Given this list of marker genes KHDRBS1, TUBB2A, NUDT4 (nudix hydrolase 4), RHOA, MTFR1, AMMECR1L (NCBI Gene Id 83607), BCL11B, BHLHE41, ID2, BASP1, BTF3L4, PRDM1, RAP2C, PHLDB1, NOG, FAM219A, REV1, EVI5, OGT, CLASP2 (cytoplasmic linker associated protein 2), CFL2, ATP2A2, PCDH8, FBXW11, SYVN1, RAC1, CDK16, TARDBP, DAG1, HIPK1, KRAS, PTHLH, BAZ2B, NUP153, SCN3B, CDK2AP1, FGFR2, AMFR, NTF3, ADCY2, PTPN13, SYT1 (synaptotagmin 1), CDK17, ORMDL3, LRP4, SLC6A1 (NCBI Gene Id 6529), FGD1, ACVR2A, UBE2I, FIGNL2, MMD2, RLF, SEMA6D, CSNK1G3, SMG8, MMD, ZMYM4, WBP1L, ZCCHC24, ARHGDIA, MATR3, LRP1, SLITRK1, FN1, OCLN, TRAPPC14, ELF2, PHF21B, NAV3, REEP1, RGL1, CNOT7, CAB39, ITPR1, KCNQ4, SESN1, PLPPR1, MPRIP, DNMT3A, HDHD2, OTUD4, TUBB, CLASP1, RAB7A, OXR1, HLF, CNOT4 (CCR4-NOT transcription complex subunit 4), TRIM33, TSC22D2, ASAP1, NPTX1, SLC16A12, LHFPL6, SOX1, LRP1B, TLN2, BMI1, RDH10, DACH1, SRSF1, EPS8, DACT1, SH3PXD2A, PDS5B, DNAJB6, SRF, MEX3C, CBX4, RHOT1, WAPL, SDC2, ATXN1, HMGB3, FEZ2, YWHAB, FMR1, TBP, UBE2W, ARPP21, GOLGA6L9 (golgin A6 family like 9), LRRTM3, TRIL, DUSP1, ARHGEF17, KCND2, MTUS1, SLC6A6, PPP2CA, PARP6 (poly(ADP-ribose) polymerase family member 6), NFIA, JAZF1, NDN, TSC22D1, ANK3, DCUN1D1 (NCBI Gene Id 54165), SYDE1, DMRT2, MYCN, UBQLN1, BPTF, CSMD3, NDST1, ANLN, CTNND2, NCOA2, NEGR1, VEZF1, TBK1, E2F3, HMBOX1, PSIP1, CILK1, ESRRG, ASXL1, SMURF2, SBF1, NIN, PIKFYVE, CDH11, KCTD8, ANKRD28, AMOTL2, MAP4K3, KRT80, PRKACB, PIN1, EGR3, SOX2, APPL1, VEGFA, DDX3X, CNN3, HSPA9, CNEP1R1, RND3, YPEL2, TMEFF2, NIPA1, LPAR1, ADIPOR2, ZFPM2, PHF6, ID2B, HECTD2, TRIM2, OSBPL11, TMEM70, CTDSPL2, SIAH1, PPP4R2, KCTD15, KLF9, WIPF1, HNRNPK, PENK, CDYL, SLC14A1, ZFAND6, KCNJ2, PCNP (PEST proteolytic signal containing nuclear protein), RTF1, FBXO33, ELOC, AEBP2, LMO7, PAM, RPS6KA2, COPS8, TRAM1L1, SSH2, TAF4, QKI, MBOAT2, NAB1, CEP350, PAPOLA, GOLGA8EP, SNAP25, GOLGA7, GNAI3, STX1A, ARID2 (AT-rich interaction domain 2), SYNJ1, SMARCD1, ARID4B, EFNA1 (ephrin A1), NCS1, MFAP5, VLDLR, RNF5, GLI3, MSL2, TOB1, NPM1, NRP2, SMARCAD1, FLI1, FNDC3B, FHL1, PUM2, FBXW2, ETV5, PLCL1, PALS1, ZC3H15 (zinc finger CCCH-type containing 15), CNTN4, TRMT9B, BRMS1L, ZIC3, XKR6, PCDH7, ERRFI1, NR3C1, ZNF217, SCAMP1, AFF3, CEP41, RABIF, KCNK2, C6orf62, HS2ST1, WDFY3, SLC16A2, PPP2R5C, NUFIP2, ZNF532, FOXG1, MBLAC2, TUBB3, AP1S2, KLF4, RANBP10, TNFRSF11B, DENND5A (NCBI Gene Id 23258), GATA2, MAP4K4, ARL8B, BRWD1, HIC2, EIF2B5, CDR2, CERS6, AMBRA1, OLIG3, NXPH1, LCP1, CREB5, UBE2B, CNTFR, IER5, SPTB, HNRNPH2, PPP2R2C, PPP6R3, ELAVL2, CNOT6, RIC1 (NCBI Gene Id 57589), CRKL, HAPSTR1, MAP2, SRSF2, CORO1C, PLS3 (plastin 3), CACNA1C, SLC1A2, NYAP1, SULF1, GDI2, FAM118B, NGEF, PPM1F, SERINC1 (serine incorporator 1), FOXK1, SCRT2, GLRA2, KLF12, PARD6B, PDIK1L, VAT1L, PCMTD1 (NCBI Gene Id 115294), MSN, PLPP3, BAG6, NR5A2, HNF1B, CYP1B1, CITED2, FAM76B, GARRE1, ARHGAP20, IGSF3, ZEB2 (zinc finger E-box binding homeobox 2), R3HDM2, SGIP1, DDX3Y (DEAD-box helicase 3 Y-linked), NOVA1, PAK5, SUPT20H, GOLGA8G, UBE2D1, AGFG1, GOLGA8B, NAPB, BCAP29 (B cell receptor associated protein 29), SEMA3F, RANBP9, PPP1R10, CRH, ZC3H6, SCHIP1, GATA4, RBSN, B3GNT2, RAP1B, ASF1A, ZEB1, EFNB2, IP6K1, MEX3B, VASH1, CASR, BAP1, SCD, DLC1, PDCD10, EIF2S1, LIN7B, XIAP, SLC23A2, UBA6, CHD9, KLHL3, GABPA, INTS8, YWHAG, ULK2, DCAF7, HNRNPD, FBXW7, GEM, PM20D2, PHF21A, GPM6A, PPM1E, SEC23A, LEPR, FAM8A1, ACACA, PLK2, MARCKS (myristoylated alanine rich protein kinase C substrate), USP25, PTBP1, S100PBP (S100P binding protein), PTPRZ1, SLC38A4, ACE2, MGAT2, CLIC4, FHOD1, MIEF1, YTHDF3, DGKA, DNAJB5, LFNG, MAFG, CLIP1, KAT2B, TOGARAM1, THAP1, PRKAR2B, FXR1, CCNJ, HNRNPU, NCOA7, JAKMIP3, NAP1L5, FXR2, NEDD1, MED13, CLIP2, DYRK2, SPTSSA, CCNYL1 (cyclin Y like 1), PHACTR3, RPS6KA3, TIAL1 (TIA1 cytotoxic granule associated RNA binding protein like 1), ZNF711, PKIA, LAMC1, MYT1, EIF5B, EGLN1, GOSR2, GPR146, MYB (NCBI Gene Id 4602), PALM2AKAP2, SLF2, FERMT2, ATRX, ADAMTS3, NRIP1, ST6GALNAC5, ETS1, NPC1, PPP1R9B, TBC1D22B, PPM1B (protein phosphatase, Mg2+/Mn2+ dependent 1B), NBR1 (NBR1 autophagy cargo receptor), MXD3, RPS6KB1, SLC38A2, HS3ST1, LYPLA2, GABBR2, PDPK1, PKD1, KLF10 (NCBI Gene Id 7071), RAB21, AKAP7, RECK, NFYA, KANK1, PHTF2, CALU, GOLGA8A, TEAD1, GIT2, TMCC1, here is a description of the gene set: Genes having at least one occurence of the motif CAGTATT in their 3' untranslated region. The motif represents putative target (that is, seed match) of human mature miRNAs hsa-miR-200b, hsa-miR-200c and hsa-miR-429 (v7.1 miRBase). studied in species Homo sapiens Human Gene Set: CAGTATT_MIR200B_MIR200C_MIR429